The following is a description of a gene set: Human Gene Set: ARID3B_TARGET_GENES studied in species Homo sapiens from publication Yevshin I, Sharipov R, Kolmykov S, Kondrakhin Y, Kolpakov F (PMID 30445619) Genes containing one or more binding sites for (ARID3B) in their promoter regions (TSS -1000,+100 bp) as identified by GTRD version 20.06 ChIP-seq harmonization., and this is the list of marker genes: PRKCH, COX7CP4, CDH8, GRM6, PRF1, CEP350, CCDC181, EIF3M, MFSD12, EHD1, RNU4ATAC4P, RBM4B, TRGJ1, HSD17B3, ANKRD20A8P, PPIAP88, LCNL1, PIP5K1B (NCBI Gene Id 8395), TCEAL3, DPP3, KRTAP9-8, NACAP6, PASK, MAP9-AS1, FAM230G, GAL, RPTOR, CCDC39-AS1, CD44, RN7SKP1, FAM13C, BRD1, LINC02607, RN7SL413P, ADCY2, CDCA4P2, ZNF410, PHF3, TGFB2-AS1, VN2R10P, CHRM3-AS2, LINC02248, FJX1 (four-jointed box kinase 1), CLEC18B, CDK17, PAX6, MCOLN1, PTPN1, FDX1P1, H3Y1, MTND2P29, FRG1EP, TRAPPC9, PAPLN, FRG1HP, SHANK2, ADCY10P1, PTGER4P2, KCTD19, TTLL7-IT1, LINC00922, PARN, ATXN2, CEP72, JARID2-DT, SLC4A8, BTG4, IGHV3-41, GDF9, NCOA4, KATNBL1P2, IQGAP1, PYGO2, AOPEP, ITGA7 (integrin subunit alpha 7), TRA2A, TNNT3, MPPED2, FAM120A, RPS24P9, ZMYND19P1, ANGEL1, RIN1, MIR34C, ZKSCAN8P2, PGS1, COLEC12, ADCK1, CEP192, NUBP1, MRPS7, LINC02630, OR2W1-AS1, MS4A3, NCOA6, STMND1, DNAJC19P1, CLDN4, CATSPER2P2, GUSBP18, NUP54, EIF3FP1, NUDCD3, HIPK1, HNRNPA3P9, SPEF2, MALAT1, LINC02736, MIR1343, KNTC1, UNC5B-AS1, ITGAE, H1-10, NBPF1, MUC6, ATP5MFP3, BZW1P1, TRAV4, RBM4, RASGRP2, SSR2, LINC02593, RNVU1-32, P3H2, LINC01833, ENAHP1, DPP3-DT, DMAP1, IL9RP4, PPP2R3A (protein phosphatase 2 regulatory subunit B''alpha), CAPN1, STX12, HDLBP, DCAF8, IGHVIII-22-2 (NCBI Gene Id 28349), IQCG, QRFP, PIM3, C1orf162, OASL, C4BPB, PRIM2, ROCK1P1, ADAMTSL5, PFN1P1, CX3CR1, RN7SKP226, BRCA1, ITPRIP, CCNYL2, TGFB2, JARID2, USP48, OTULIN (NCBI Gene Id 90268), LRRC34P1, MYC, FBRS, TRIB1AL, BCAR3-AS1, GSE1, C11orf68, DRAP1, ZNF84, DLGAP1-AS4, CYB5RL, GGA3, C1orf185 (NCBI Gene Id 284546), ARID1A, ENSG00000215156, TMEM38BP1, IGHVII-30-1, ATP6V1D, PTPN2P1, EXOSC10, MCUR1, PLCG2, BRF1, SIGLEC30P, GSAP, RN7SKP118, MYH11 (NCBI Gene Id 4629), ZC3H7A, CA11, TC2N, UBE2D3P2, LINC00470, ENTPD8, TSIX, IGHVII-22-1, TENM2, RPS29P3 (ribosomal protein S29 pseudogene 3), NSF, SLC35F3-AS1, LRRC74A, RN7SKP239, ATG16L2, RFKP5, TNRC6A (trinucleotide repeat containing adaptor 6A)